Given this list of marker genes IL10, ST14, RSPO3, LLGL2, FGFR2, SPINT1, ADM (NCBI Gene Id 133), GRHL2 (NCBI Gene Id 79977), TMED2, FZD5, GCM1, GRB2, SOCS3, SPINT2, here is a description of the gene set: The process in which the branches of the fetal placental villi are generated and organized. The villous part of the placenta is called the labyrinth layer. Human Gene Set: GOBP_BRANCHING_INVOLVED_IN_LABYRINTHINE_LAYER_MORPHOGENESIS studied in species Homo sapiens